Given this list of marker genes THBS2, ADAMTSL3, ELN, MFAP4, COL6A3, GPC3, MATN2, LUM, FSTL1, C7, LTBP4, COL21A1, ADAMTS2, ITM2A, EPB41L2, ANGPTL2, COL6A6, PCOLCE, RRBP1, LAMC1, PEG3 (NCBI Gene Id 5178), COL5A1, COL16A1, MRC2, COL15A1, DPT, OLFML1, SERPINF1, PLAC9, CPQ, S1PR2, LSP1P5, SNAI2, IGFBP7, CCDC102B, FKBP7, LRP1, LRRC17, TGFBI, TIMP1, PTN, DCN, SGCE, LAMA4, THY1, OGN, FBN1, FILIP1L, COL6A2, GPC6, FBLN2, RCN3, MOXD1, NID1, SERPING1, COL5A2, SRPX, EBF2, KCTD12, NFIA, FBLN1, COL12A1, COL1A2, SDC2, MFAP2, CYBRD1, MEST, FLRT2 (NCBI Gene Id 9822, fibronectin leucine rich transmembrane protein 2), ISLR, COL14A1, DLK1, TCF21, P3H1, LSP1P4, C1R, AKAP12, LGALS1, MMP2, COL6A1, HTRA3, FRZB, RCN1, SELENOM, FBLN5, ABCA8, LOX, IL32, TIMP2, PRDX4, SEPTIN11, FNDC1, PLAGL1 (PLAG1 like zinc finger 1), GLT8D2, BICC1, COL1A1, SPON2, CXCL12, PCDH18, SPRY1, SERPINE2, SMOC2, NRK (Nik related kinase), CCN2, ASPN, SCN7A, MEG3, SPON1, MXRA8, OLFML3, SERPINH1, PDGFRA, NUPR1, SPARC, LAMB1, C1QTNF2 (C1q and TNF related 2), EFEMP2, MGP, here is a description of the gene set: from publication Cui Y, Zheng Y, Liu X, Yan L, Fan X, Yong J, Hu Y, Dong J, Li Q, Wu X, Gao S, Li J, Wen L, Qiao J, Tang F (PMID 30759401) Human Gene Set: CUI_DEVELOPING_HEART_C3_FIBROBLAST_LIKE_CELL species: Homo sapiens